The following is a description of a gene set: Mouse Gene Set: MIR_290A_3P Genes predicted to be targets of miRBase v22 microRNA mmu_miR_290a_3p in miRDB v6.0 with MirTarget v4 prediction scores > 80 (high confidence targets). species: Mus musculus from publication Chen Y, Wang X (PMID 31504780), and this is the list of marker genes: Prdm8, Prr23a1, Rab5c, Zc3h12c, Rtn1, Ssbp1, Skida1, Miga2, Tfap4, Trmt2a, Zfp367, Npas2, Zfp148, Arhgef12, Slc25a13, Arid4a (NCBI Gene Id 320602), Scml2, Mef2a (NCBI Gene Id 320979), Fat2, Synpo2, 2010106E10Rik, Dkk1 (NCBI Gene Id 13380, dickkopf WNT signaling pathway inhibitor 1), Ago1, Znrf3, Oga, Rab5b, Rrm2, Nfx1, Ankrd9, Dixdc1, Ahcyl1, Cpeb1, Dnajb3, Fgf9, Epha7, Nol4l, Myrf, Hp1bp3, Lman2, Kif5b, E2f2, Cxcr4, Osr1, Thsd7a (NCBI Gene Id 671480), R3hdm1, Irf4, Tenm2, Rbl2, Dcun1d3, Chd5, Tapt1, Arhgef28, Baz1b, Dync1li2, Arid4b, Dazap2, Mrtfb, Mob1b, Bin3, Zbtb7a, Dll1, Vps26a, Tnik, Kcnd2, Suv39h1, Stil, Lratd2, B3galt2, Lamp5, Ube3c, Cep170, Hipk3, Nedd4l, Eif5a2, Ppp2r2a, Zfhx4 (zinc finger homeodomain 4), Caprin2, Dpysl5, S1pr1, Mat2b, Ccng2, Myoz2, Rcan3, Rtn4, Clock, Mylk, Sertad2, Phf1, Kdm1b, Ikzf2, Foxj3, 2510009E07Rik, Arhgap26, Mtmr4, Pafah1b2, Angel1, Tmem38b, Rnf216, Zbtb41, Igsf10, Ifi209, Casp2, Nbea, Nr4a2